Given this list of marker genes Casp3, Inka1, Prkar1a, Cit, Hexim1, Akt1s1, Prkch, Spred1, Cdkn2a, Smo, Pkig, Prkar2b, Cdkn2c, Prkag2, Kat2b, Macroh2a1, Pkib, Cdkn1a, Atad3a, Ppef2, Prex1, Cdkn1c, Spred2, Pkia, Ankrd42, Deptor, Pmp22 (peripheral myelin protein 22), Prkar2a, Prex2, Camk2n1, Cdkn1b, Cib1, Hspa5, Cdkn2b, Htra2, Akt1, Hexim2, Wnk1, Prkar1b, Inka2, Camk2n2, Inca1, Rptor, Cdkn2d, Hspb1, here is a description of the gene set: Binds to and stops, prevents or reduces the activity of a protein serine/threonine kinase. Mouse Gene Set: GOMF_PROTEIN_SERINE_THREONINE_KINASE_INHIBITOR_ACTIVITY studied in species Mus musculus